The following is a description of a gene set: part of: Cell Cycle, Mitotic studied in species Homo sapiens Mitotic G1-G1/S phase involves G1 phase of the mitotic interphase and G1/S transition, when a cell commits to DNA replication and divison genetic and cellular material to two daughter cells.<p>During early G1, cells can enter a quiescent G0 state. In quiescent cells, the evolutionarily conserved DREAM complex, consisting of the pocket protein family member p130 (RBL2), bound to E2F4 or E2F5, and the MuvB complex, represses transcription of cell cycle genes.<p>During early G1 phase in actively cycling cells, transcription of cell cycle genes is repressed by another pocket protein family member, p107 (RBL1), which forms a complex with E2F4. RB1 tumor suppressor, the product of the retinoblastoma susceptibility gene, is the third member of the pocket protein family. RB1 binds to E2F transcription factors E2F1, E2F2 and E2F3 and inhibits their transcriptional activity, resulting in prevention of G1/S transition. Once RB1 is phosphorylated on serine residue S795 by Cyclin D:CDK4/6 complexes, it can no longer associate with and inhibit E2F1-3. Thus, CDK4/6-mediated phosphorylation of RB1 leads to transcriptional activation of E2F1-3 target genes needed for the S phase of the cell cycle. CDK2, in complex with cyclin E, contributes to RB1 inactivation and also activates proteins needed for the initiation of DNA replication. Expression of D type cyclins is regulated by extracellular mitogens. Catalytic activities of CDK4/6 and CDK2 are controlled by CDK inhibitors of the INK4 family and the Cip/Kip family, respectively. Reactome Pathway: Mitotic G1 phase and G1/S transition, and this is the list of marker genes: MCM3, CDKN1B, PSMA3, ADRM1, PPP2R3B, FBXO5, PSMC4, PSMD7, POLA2, CDC45, RPA2, CABLES1, MAX, PSMD8, TYMS, E2F2, CDK6, CCNE1, PSMD6, PSMB7, TOP2A, ORC5, RBL2, E2F3, AKT1, MCM5, MCM2, PSMD13, ORC3, E2F1, DHFR, GMNN, MCM8, PSMB2, PRIM1, ORC6, CDKN2D, POLE, CDKN2C, TFDP1, PSMD12, PSMA2, CDT1, DYRK1A, PSMD14, MYBL2, PSMB3, RRM2, ORC1 (origin recognition complex subunit 1, NCBI Gene Id 4998), PPP2R2A (protein phosphatase 2 regulatory subunit Balpha), ABL1, POLA1, LIN54, CCND1, CDK7, SKP2, LIN37, CCND3, MCM6, AKT2, PSMD11, POLE4, RPA3, DBF4, LYN, MNAT1, JAK2, PSMD3, PTK6, CCNE2, PSMA6, PSMC1, WEE1, CCND2, PSMB6, CDK1, MCM10, PSMC5, CDC7, PRIM2, PSMB4, CDC6, PPP2CA, CDKN2B, PSMD1, ORC2, PPP2CB, PSMB1, PSMC6, SRC, PSMC3, RPA4, PSMB5, MCM7, PPP2R1A, PSMA7, LIN9, PSMC2, PPP2R1B, PSMA4, PSMA5, CKS1B, RPA1, SEM1, CUL1, SKP1, CDKN2A, CCNH, MYC, TK1, CDK2, CDKN1C, RBBP4, AKT3, RPS27A, CDKN1A, CCNB1, RBL1, E2F5, PSMA1, MCM4, RB1, PCNA, LIN52, E2F6, POLE2, CDC25A, E2F4, POLE3, CCNA2, PSMD2, HDAC1, TFDP2, CCNA1, UBA52 (NCBI Gene Id 7311), ORC4, UBB, CDK4, UBC